The following is a description of a gene set: studied in species Homo sapiens from publication Lin JX, Li P, Liu D, Jin HT, He J, Ata Ur Rasheed M, Rochman Y, Wang L, Cui K, Liu C, Kelsall BL, Ahmed R, Leonard WJ (PMID 22520852) Cytokine-activated STAT proteins dimerize and bind to high-affinity motifs, and N-terminal domain-mediated oligomerization of dimers allows tetramer formation and binding to low-affinity tandem motifs, but the functions of dimers versus tetramers are unknown. We generated Stat5a and Stat5b double knock-in (DKI) N-domain mutant mice that form dimers but not tetramers, identified cytokine-regulated genes whose expression required STAT5 tetramers, and defined consensus motifs for dimers versus tetramers. Whereas Stat5- deficient mice exhibited perinatal lethality, DKI mice were viable, indicating that STAT5 dimers were sufficient for survival. Nevertheless, STAT5 DKI mice had fewer CD4+CD25+ T cells, NK cells, and CD8+ T cells, with impaired cytokine-induced proliferation and homeostatic proliferation of CD8+ T cells. DKI CD8+ T cell proliferation following viral infection was diminished and DKI Treg cells did not efficiently control colitis. Thus, tetramerization of STAT5 is dispensable for survival but is critical for cytokine responses and normal immune function. Human Gene Set: GSE36888_STAT5_AB_KNOCKIN_VS_WT_TCELL_IL2_TREATED_6H_UP Genes up-regulated in T cells stimulated by IL2 for 6h: STAT5 double knock-in versus wildtype., and this is the list of marker genes: DYNLT5, GYG1, MDP1 (magnesium dependent phosphatase 1), FAM234B, NR6A1, TALDO1, RBBP4, CXCL11, MED23, GALNT15, MTRES1, ATP8A2, IGFLR1, PFKFB4 (NCBI Gene Id 5210), ASXL2, LRRTM4, POSTN, RCSD1 (RCSD domain containing 1), MDK, CGAS, SLC35A3, SC5D, LYL1, MSL2, APBA2, HVCN1, COPG2, NINJ1, GIMAP7, PDIA2, PCDHB14, ESPN, KCNK4, NLRC5, SLC5A7, SLC28A2, GPR152, KLHL35, DRC1, GIMAP1, SCRN3, CEBPB, MTMR4, IL21R (interleukin 21 receptor), WDR59, CDYL2, DAZAP1, NMRAL1, ACYP1, MCCC2, RPAP2, DAP3, HELB, NABP1, ITGB2, ACP2, CXXC1, SLFN13, RHOB, PTGER4, TMEM126A, POLR2A, DYRK3, BCKDK (branched chain keto acid dehydrogenase kinase), SRP54, C17orf75, PTPRE, AREL1, SOX5, ADM, DYNLRB1, SIPA1L2, FUNDC1, KDM6A, DYNC2I1, GRINA, HNRNPD, IFNAR1, KCTD2, TGDS, RNF139, MIX23, CUL3, PSMG2, ASRGL1, TBC1D4, PIK3AP1, CDK2AP1, STAU2, ZSWIM4, TBCE, LINC00612, YPEL5, PDE7A, BORCS8, HMG20A, HEXA, RASA1, GRAMD1A, EPB41L2 (erythrocyte membrane protein band 4.1 like 2), CLN3, GRIN3A, OSBPL3, KLHDC2, GPC5, PACSIN1, SYTL4, DUSP2, SMIM8, SGSH, SMIM19, B4GALNT1, USP45, BEND6, IL4, H2AC18, RPP21, PHF21A, TM9SF3, CRX, MARCHF4 (membrane associated ring-CH-type finger 4), FYB1, IFIT2, SUCO, GAPDHS, RIGI, TRIP4, CLCN7, SYNE2, MVB12B, SH3KBP1, CD200R1L, SEPTIN7, USP5, LYRM2, GCDH, KHDRBS1 (NCBI Gene Id 10657), MYO9B, LRRK1, FGL2, AFF2, MRPS21, IFIH1, ZNF569, SLAMF6, UST, CASP8, PITPNA, SLC10A3, REG4, QRSL1, C2orf68, GHSR, AGPAT3, CHCHD10, AQP9, IRF7, DTNBP1, FHIP2B, OSR1, WDR33, MAPKBP1, KLHL17, FBXW7, SH3BGRL3, ARSB, CAMK2A, ERCC5, MUC5B, IL36RN, TCF20, CD69, JCAD, MYADML2, CBLB, SDCBP, ISG15, TXK (TXK tyrosine kinase), SPRTN, COMMD4, CYB5B, CD3G, FAF1, ERCC6L2, PSPC1, TASP1, EXOC1, TRDMT1, BRCA2, PRDX2, ARHGAP10, PHYKPL, STK17B, GDPD3, HGS, SEPHS2, ADGRE5, TBC1D2B, DDT